Given this list of marker genes Crhr1, Oprk1, Adora2b, Drd3, Cartpt, Snca, Pink1, Ptgs1, Syt7, Sdhd, Oxtr, Oxt, Cxcl12, Chrna4, Npy2r, Myo5a, Crhr2, Gabbr1, Rab3a, Chrnb2, Syt1, Ffar3, Adora3, Kcna2, Grm2, Slc18a1, Prkcb, Stx1a, Abat, Sncg (synuclein, gamma), Cnr1, Syt4, Rtn4, Ptger3, Htr2a, P2ry1, Drd2, Htr1b, Adora2a, Pcp4, Chrna6, Chga, Hrh3, Ghsr, Gck, Agtr2, Dtnbp1, P2ry12, Plcd1, Htr6, Syt11, Kcnb1, Chrna7, Entpd1, Crh, Agt, Grk2, here is a description of the gene set: Any process that modulates the frequency, rate or extent of the regulated release of catecholamines. studied in species Mus musculus Mouse Gene Set: GOBP_REGULATION_OF_CATECHOLAMINE_SECRETION